The following is a description of a gene set: part of: Diseases associated with glycosaminoglycan metabolism Reactome Pathway: Defective B4GALT7 causes EDS, progeroid type studied in species Homo sapiens Ehlers–Danlos syndrome (EDS) is a group of inherited connective tissue disorders, caused by a defect in the synthesis of collagen types I or III. Abnormal collagen renders connective tissues more elastic. The severity of the mutation can vary from mild to life-threatening. There is no cure and treatment is supportive, including close monitoring of the digestive, excretory and particularly the cardiovascular systems. Defective B4GALT7, a galactosyltransferase important in proteoglycan synthesis, causes the progeroid variant of EDS (MIM:130070). Features include an aged appearance, developmental delay, short stature, generalized osteopenia, defective wound healing, hypermobile joints, hypotonic muscles, and loose but elastic skin., and this is the list of marker genes: VCAN, NCAN, GPC2, GPC6, GPC3, GPC5, CSPG5, BGN, GPC4, BCAN, HSPG2, SDC1 (NCBI Gene Id 6382), CSPG4, SDC4, DCN, B4GALT7, GPC1 (NCBI Gene Id 2817), SDC2, AGRN, SDC3